The following is a description of a gene set: part of: Signaling by PTK6 Reactome Pathway: PTK6 Regulates Proteins Involved in RNA Processing This event has been computationally inferred from an event that has been demonstrated in another species.<p>The inference is based on the homology mapping from PANTHER. Briefly, reactions for which all involved PhysicalEntities (in input, output and catalyst) have a mapped orthologue/paralogue (for complexes at least 75% of components must have a mapping) are inferred to the other species. species: Mus musculus electronically inferred by orthology from the curated human pathway, and this is the list of marker genes: Khdrbs1, Khdrbs2, Khdrbs3